Given this list of marker genes TREX1, POT1, SASH3, NGLY1, STX5, GIMAP5, here is a description of the gene set: Diffuse benign transformation of the hepatic parenchyma into small regenerative nodules with minimal or no fibrosis. Nodular regenerative hyperplasia of liver Human Gene Set: HP_NODULAR_REGENERATIVE_HYPERPLASIA_OF_LIVER studied in species Homo sapiens